Given this list of marker genes SEL1L3, PLXDC2, COL3A1, DAB2, SIPA1L1, RASGRF2, BACE2, MGP, HOXB6, LIFR, ME1, ALDH6A1, PPP1R3B, PCDHB14, TSHZ2, TAGLN, WT1, DIO2, ZNF703, MAP3K4-AS1, CD109, TIMP2, CFH, VAT1L, KCNC4, CD24, PRRX1, SLC16A7, STON2 (stonin 2), CALD1, MAP3K8, ATP11C, MRPL30, GJB2, PRRX2, ANG, AMIGO2, TNFRSF19, ITGB3, C1S, IGFBP6, SPOCD1, ANOS1, TCEAL8, ZNF521, OXTR, ERI1, STOM, FBXO32, CD55 (NCBI Gene Id 1604), PLAT, SYNE3, CADM1, ITGA2, HMCN1, RHOJ, CTHRC1, SLFN5, FN1, RHOBTB3, RPL37, IQGAP2 (IQ motif containing GTPase activating protein 2), CFI, GSN, KLHDC7B, JCAD, SERPINB4, PTPN13 (protein tyrosine phosphatase non-receptor type 13), ANKRD44, GABRA2, PARVA (NCBI Gene Id 80050), HOXB7, KLHL24, CYBRD1, DSG2, PLP1, ANTXR1, CEMIP2, PLXND1, TLL2, MARCKS, SERPINB3, JAG1, BEX3 (NCBI Gene Id 27018), MATN2 (NCBI Gene Id 4147), TGFB1, MKX, TDO2, SPOCK1, MAN1C1 (NCBI Gene Id 57134), RARRES1, FKBP7, MAFB, ALDH1L2 (aldehyde dehydrogenase 1 family member L2), RTN1, LINC00968, KIZ, DACT1, GLIPR2, DIRAS1, FNDC1, SAMD5, TLE3, EDIL3, PLEKHG4B, DIP2B, PROS1, SIPA1L2, MYOCD, NAP1L3, KLRC1, FLRT3, COL8A1, TLCD2, SRPX, BCAT1, MAN2A1, BTD, SLC22A17, IFIT3, LRRFIP1, TCEAL9, STEAP1, COL12A1, PRG4, RBMS1, PCDH7, CLEC2B, SERINC5, ROR1, ACAN, NLGN4X, IPMK, SULF2, SLC44A1, PCYOX1, TES, GHR, HS3ST3B1 (NCBI Gene Id 9953), WARS1, IGFBP4, NIPSNAP3A, GABBR2, MFAP5, PRR5L, SDC2, KLF7, PMP22, CHI3L1, ETV6, SULF1, MYLK, EPAS1, HIPK3, CD200, TMEM108, CGNL1, KRCC1, AKIRIN2, NUCB1, TBX18, BCAM, SMTN, FRY, PERP, PLCB1, PCDHB2, DLL1, TCIM, TXNIP, CTDSP2, MFF, CA12, POU3F3, FIBCD1, TOX2, DPYD (dihydropyrimidine dehydrogenase), PCDH10, NPR3, ATP10D, COL1A1, PLD3 (phospholipase D family member 3), ITGB8, CYLD, LIMS1, SNX18 (NCBI Gene Id 112574), PTGFRN, FRAS1 (NCBI Gene Id 84949), COL5A1, LMCD1, LBH, FOXO1, CCN4, DLX6, ATP9A, SPTLC3, ABCA1, PCDHB10, TGFB2, PAWR, NUPR1, UNC5B, FZD1, MCF2L2, S1PR3, SERPINB7 (serpin family B member 7), BICD1, KRT18, HEG1, DENND2B, AVIL, RAB27A, NRIP1, HOXB5, TGFBR1, PLAG1, ABTB3, IFIT2, MYL9, FAP, GSX2, ZNF711, CASK, STRBP, PLSCR4, ATL3, LUM, INHBB, IL1R1, IL13RA1, FBLIM1, IER5L, PGM2L1, ITM2A, GATA3, MAP1B, LNPK, VCAN, CD24P2, NEXN, ITGB5, FHL2, LIMA1, NID1, DCN, EEIG1, LPCAT2, ADD2 (adducin 2), IRS1, ATXN1, RNF144A, GALNT12, GULP1, COL6A3, POSTN, CCDC71L, PTX3, DACH1, NID2, CPE, MMP2 (NCBI Gene Id 4313), TGFBI, GRB10, SOCS3, NTRK2, F2R (NCBI Gene Id 2149), VLDLR, SBSPON, PRSS35, CA4, JDP2, SOCS2, RNASE4, TPBG, LPP, SMIM14, H2BC7, ATP8B1, MCC, ACTA2, TRIB2, DPYSL3, IGFBP5, BOC, CBLB, GNG2, BMPR2, SLC12A8, NEGR1, COL15A1, RPL31P46, HS6ST2, KLHL28, here is a description of the gene set: Mutation of BRG1, hBRM, and their associated factors, INI1 and BAF57, in primary human tumors has suggested that inactivation of human SWI/SNF (hSWI/SNF) complexes may be involved in neoplastic transformation. BT549 is an invasive human breast carcinoma cell line that lacks expression of BAF57, a key hSWI/SNF subunit that mediates interaction with transcriptional activators and corepressors. In this study we investigated the role of BAF57 in suppressing tumorigenesis by establishing BT549 stable cell lines that expresses full-length BAF57 protein. BT549 clones expressing BAF57 demonstrated marked phenotypic changes, slow growth kinetics, and restoration of contact inhibition. Altered growth was found to be due in part to cell cycle arrest and induction of apoptosis. Furthermore, microarray analysis revealed that BAF57-mediated cell death was associated with up-regulation of proapoptotic genes including the tumor suppressor familial cylindromatosis (CYLD), which was found to be a direct target of BAF57 as determined by chromatin immunoprecipitation analysis. Increased expression of CYLD in BT549 cells induced apoptosis, while its suppression by small interfering RNA inhibited cell death in BAF57 expressing BT549 cells. These findings demonstrate the importance of BAF57 in cell growth regulation and provide a novel link between hSWI/SNF chromatin remodelers and apoptosis. Human Gene Set: WANG_SMARCE1_TARGETS_UP Genes up-regulated in BT549 cells (breast cancer) by expression of SMARCE1 off a retroviral vector. studied in species Homo sapiens from publication Wang L, Baiocchi RA, Pal S, Mosialos G, Caligiuri M, Sif S (PMID 16135788)